Given this list of marker genes Nme1, Eps8l3, Pdxp, Slc34a2, Slc5a8, Slc17a4, Cd24a, Gabra2 (NCBI Gene Id 78710), Bbs9, Aif1, Bmx, Arhgap45, Aqp7, Rasgrp2, Amn, Slc5a6, Hsp90ab1, Pde9a, B4galt1, Pik3cb (NCBI Gene Id 74769), Eps8l1, P2ry12, Tiam1, Them4, Kcnh1, Grin2a, Gucy2d (guanylate cyclase 2d), Bbs5, Smo, Muc4, Gabrg2, Cdkl5, Plek2, Cnga4, Ndrg4, Cubn, Ttyh1, Gnb1, Kcnc3, Mapk8ip3, Cib1, Fgr, Syne2, Itln1, Plb1, Kcnc2, Clrn2, Slc9a5, Mtmr6, Ninj1, Epb41l3, Twf1 (NCBI Gene Id 19230), Kcnc1, Tmem67, Sh3bgrl3, Evc2, Dlc1, Ift46, Pak1, Slc26a6, Kank1, Micall1, Pip5k1a, Mfsd10, Itgav, Akt2, Cd36, Pde6g, Apc, Spry2, Ctnnb1, Slc7a8, Dpp4 (NCBI Gene Id 13482), Ptger3, Fermt1, Ehd3, Fzd9, Kcnc4, Abcc2, Kcnk1, Hsp90aa1, Ezr, Gabra1, Myo10 (myosin X), Atp2b1, Epha2, Rdh11, Psd2, Slc28a1, Slc34a1, Eef1a1, Arhgef2, Gabra6, Plcg2 (NCBI Gene Id 234779), Fermt2, Dmd, Shank3, Psd3 (NCBI Gene Id 80295), Dagla, Itga5, Gna12, Slc5a2, Ush2a, Reg1, Slc6a19, Gabre, Tmem17, Chrna7, Sstr3, Rac1, Phlpp2, Atp8b1, Ace, Slc11a2, Hcn2, Mxra8, Gabra5, Car4, Insr, Prom2, Erbb2, Unc5a, Plxnd1, Tas2r108, Myo1c, Sh3yl1, Dmtn, Cfl1 (NCBI Gene Id 12631), Atf4, Mtss2, Rapgef3, Gpr157, Slc22a21, Slc5a1, Abcg3, Car9, Atp7a, Nckap1, Slc6a20b, Cdhr1, Arl6, Dnm2, Jcad (junctional cadherin 5 associated), Spry4, Mpp2, Slc1a2 (solute carrier family 1 (glial high affinity glutamate transporter), member 2), Ptprz1, Pkd2, Spata13, Gria1, Slc12a5, Ppp1r9b, Epb41l5, Fscn1, Pkhd1l1, Ceacam20, Slc7a5, Atp2b2, Hpca, Gria2, Rigi, Gpr88, Txndc15, Prcd, Myo6, Tpm1, Slc6a18, Umod, Shisa6, Slc9c1, Pkd2l1 (polycystic kidney disease 2-like 1), Cys1, Snap29, Aqp8, Trpv1, Cspg4, Wls, Vasp, Plekho1, Gap43 (growth associated protein 43), Cdhr5, Slc6a14, Bbs4, Gpr37l1, Slc27a4, Prkcb, Drd5, Ehd1, Pcmt1, Dpep1, Trpc2, Sntg1, Pde6h, Cnga2, Gabrg1, Atp1b2, Arf6, Hip1r, Pdzk1, Itga3, Slc28a3, Eps8l2, Gabarapl1, Pde6b, Thy1, Trpm6, Shisa8 (shisa family member 8), Slco1a5, Fgd5, Aqp1, Cltrn, Slc34a3, Kcnn4, Cacna1d, Coro1c, Src, Slc22a12, Dock8, Cltb, Slc7a9, Bbip1, C2cd5, Rab25, Cnga1, Piezo1, Fscn3, Sptbn1, Pth1r, Scarb1, Itgb3, Ngfr, Pkd1l1, Eps15, Psd4, Rhoa, Kcna2, Plekha1, Tesc, Pip5k1c, Itgb1, Sh2d3c (NCBI Gene Id 27387), Eps8, Gpr161, Ceacam1, Rab8a, Ace2, Utrn, Slc3a1, Ddn, Nradd, Bves, Ffar4, Plcg1, Oprd1, Cask, Gucy2e, Rom1, Stx4a, Ank1, Gabra3, Npc1l1, Slc28a2, Lima1, Robo1, Gabbr1, Slc22a5, Kirrel1, Inpp5j, Shisa9, Adora1, Arl13a, Map2, Rps3, Slc26a4, Clasp2, Cdc42, Lcp1, Podxl, Shank2, Atp6ap2, Appl2, Ksr1, Folr1, Gpi1, Cd44, Grin1, Slc26a2, Itga8, Wwc1, Mcoln3, Sgce, Slc39a6, Gabra4, Prph, Akap5, Antxr1 (NCBI Gene Id 72182), Drd2, Apc2, Tbc1d10c, Tspear, Scimp, Adcy6, Aqp4, Tln1, Abca7, Slc38a4, Iqce, Mosmo, Adora2a, Slc46a1, Hcn1, Myo1d, Arl13b, Ttc8, Pld2, Gna13, Pla2g4f, Pacsin2, Slc19a1, Atp6v0a4, Lamp5, Arpc2, Abcg2, Ripor2, Fgd2, Gper1, Pde6a, Cntnap2, Clcn2, Egfr, Ptprh, Mapre1 (microtubule-associated protein, RP/EB family, member 1), Gabrg3, Enpep, Lrp2, Anpep, Aif1l, Evc, Kcnb1, Slc7a11, Palm, Rab35, Bbs1, Msn, Synj2, Arf4, Slc6a6, Mapt, Amn1 (NCBI Gene Id 76107), Pemt, Fap, Adam17, Psd, Plek, Septin2, Cdhr2 (NCBI Gene Id 639588), Inpp5k, Bbs7, Drd1, Pdpn, Slc20a2, Efcab7, Abcb1a, Shisa7, Slc26a3, Bbs2, Rho, Pex19 (peroxisomal biogenesis factor 19), Diaph1, Mtmr9, Adgrv1, Scnn1a, Cybrd1, Pacsin1, Slc9a3, Fam107a, Macf1, Muc20, Arpc1a, Trpv4, Oprm1, Adcy3, Cacng8, Cdc37, Nherf1, Robo2, Tacr3 (NCBI Gene Id 58183), Tmem231, Ptprj, Slc2a2, Entpd2, Mttp, Tirap (toll-interleukin 1 receptor (TIR) domain-containing adaptor protein), Kcnj11, Prom1, Mchr1, Dlg1, Vezt, here is a description of the gene set: The portion of the plasma membrane surrounding a plasma membrane bounded cell surface projection. studied in species Mus musculus Mouse Gene Set: GOCC_CELL_PROJECTION_MEMBRANE